The following is a description of a gene set: Human Gene Set: GOMF_PROTEIN_TRANSPORTER_ACTIVITY Directly binding to a specific protein and delivering it to a specific cellular location. studied in species Homo sapiens, and this is the list of marker genes: DNAJB2, SEC61A1, AZGP1, TOMM40, LRP2, BLOC1S3, TIMM17A, PEX6, SORL1, ATP13A1, MCL1, TIMM17B, PEX10, LMBRD1, TOMM70, GPIHBP1, TOMM20L, GGA3, TIMM29 (translocase of inner mitochondrial membrane 29), SEC61A2, SEC61G, IGF1R, ATAD1, TOMM40L, TMED10, PEX14, PEX1, PEX2, AP4M1, M6PR, TOMM22, PEX12, RHBDF2, TIMM22, PEX13, TIMM23, ABCA1, TOMM7, SEC63, TOMM20, TIMM8B, TIMM23B